Given this list of marker genes Pou5f1, Chek1, Brca2, Brd4, Zfp830, Sall4, Grn, Ints1, Gins1, Rad51b, Hbegf, Gins4, Ncapg2, Palb2, Ndel1, Dicer1, Igf1, Acvr1c, Ubtfl1, Esrrb, Taf8, Sbds, Nbn, Cops2, Ctr9, Setdb1, Smarca4, Zpr1, Dmbt1, Pelo, Rtf1, here is a description of the gene set: An increase in size of a blastocyst due to expansion of the blastocoelic cavity cell shape changes and cell proliferation. species: Mus musculus Mouse Gene Set: GOBP_BLASTOCYST_GROWTH